Given this list of marker genes Sox15, Rrm1, Kcnn4, Med1, Ccn2, Rrm2b, Orc1, Rhno1, here is a description of the gene set: A cell cycle process that activates or increases the rate or extent of the transition from the G0 quiescent state to the G1 phase. species: Mus musculus Mouse Gene Set: GOBP_POSITIVE_REGULATION_OF_G0_TO_G1_TRANSITION